Given this list of marker genes LILRB4, CD160, TNFSF4, LILRB2, CCR7 (NCBI Gene Id 1236), here is a description of the gene set: Any process that modulates the frequency, rate or extent of T cell costimulation. studied in species Homo sapiens Human Gene Set: GOBP_REGULATION_OF_T_CELL_COSTIMULATION